The following is a description of a gene set: Human Gene Set: TGCTGCT_MIR15A_MIR16_MIR15B_MIR195_MIR424_MIR497 Genes having at least one occurence of the motif TGCTGCT in their 3' untranslated region. The motif represents putative target (that is, seed match) of human mature miRNAs hsa-miR-15a, hsa-miR-16, hsa-miR-15b, hsa-miR-195, hsa-miR-424 and hsa-miR-497 (v7.1 miRBase). studied in species Homo sapiens, and this is the list of marker genes: MYT1L, ARPP21, DCAF7, TMEM87A, BCL2L2, SOBP, ZKSCAN2, SCOC, QKI, CARM1, ACSBG1, WNT3A, ZYX, APP, RPS6KA3, EIF3A, KCTD1, PLA2G15, PLEKHA1, RUNX1T1, TFAP4, NR4A3, HAS2, UBE2V1, GPR63, DLL1, DEDD, SMAD3, CLOCK, SGK1, ACSL1, VEGFA, TMEM33, EIF4B, OTUB1, CDC42, CPEB3, PCDH17, VSIR, ZCCHC3, TPPP3, PPP2R5C, LAMC1, ADCY10P1, RASL12 (NCBI Gene Id 51285), UBXN10, MIPOL1, EDA, ERC2, GRAMD2B, TMEM87B, ZBTB39, PCDHA11, HOXA3, CREBRF, ELMO2, MAP7, WBP11, VAMP7, PAFAH1B1, ARHGEF5, DYNC1I1, TLE4, PTPN3, CDC37L1, PHF20, SLC9A6, STRADB, GORASP2, ARMCX2, ARFGAP2, PCDHA3, CADM1, YWHAH, MIB1, GABBR1, MAP2K3, PCDHA12, KIF5B, SPEN, SMYD5, CSDE1, ELL, EPB41L4B, DCUN1D4, PITPNA, SIX4 (NCBI Gene Id 51804), USP25, PIM1, ATF7IP2, PURA, EPHA1, CHRD, N4BP1 (NCBI Gene Id 9683), GRIN1, ITGA2, GREB1L, YWHAQ, LMAN2L, KBTBD2, BTRC, CLASRP, CDS2, ETFRF1, OTUD4, SYDE1, CCDC28A, ESRRA, SIGMAR1, CACUL1, RNF144B, TBP, ZNF609, ARHGEF9, SCARF1, PNPLA6, CCND2, MMD, E2F7, PRDM4, BCL9L, MICU1, LRIG2, SNTB2, FGF2, ARHGAP5, CAPN6, SEH1L, WNT7A, PCDHA7, POU3F2, MYLK4, DEF8, CLCN5, PCDHA13, PPP2R1A, NEXMIF, BACH2, PIEZO1 (NCBI Gene Id 9780), SYNRG, TGIF2, PIAS1, DCBLD2, ACTR1A, KPNA4, MOB3B, ZHX1 (NCBI Gene Id 11244, zinc fingers and homeoboxes 1), ENAH, KCTD8 (potassium channel tetramerization domain containing 8), OGT, ZNF362, GHR, MTSS1, UBFD1, CHD5, PLEKHH1, LITAF, TMEM135, GNAI3, NFATC3, PCDHAC2 (protocadherin alpha subfamily C, 2), PHF19, ANGEL1, TRPM2, PPM1A, SYNE1, CCDC6, SLC7A2, VPS9D1, SPTLC1, LRP1B, ACSL4, PCDHA4, PCDHA2, POM121, SLC4A4, ANK2, KCNAB1, ZMYM6, WDR47, RNF217, TFAP2D, TCAIM, ATP2B2, SYPL1, APLN, PAK5, ADGRL2, KALRN, SELENOI, COL12A1, DACH1, EXOC3L2, NRP2, ADGRL1, MAP3K3, LATS2, CNIH2, PTCH1 (patched 1), PHF20L1, PCDH9, KREMEN2, TBPL1, GPN1, TSC22D3, ARHGAP12, ADRB2, PCGF5, ADGRB1, RAB10, LUZP1, ANKRD13B, MAPK3, SYNJ1, RARB, UBE2J1, TBL1XR1, RSBN1, TMEM255A, G0S2, KIF1B, LTB, MYLK, ZNF532, LRP6, AXIN2, CHORDC1, TFAP2A, AFF4, BCL2, RSPO3, PURB, KCNJ2 (potassium inwardly rectifying channel subfamily J member 2), RNF125, JADE2, DCAF5, SMAD7, SOCS6, CDC42EP2, PSD3, BCAP29, IL17RE, EPHA7, RYBP, NUP50, AHCYL2, CUL2, PDCD4, TMCC1, CALM1, WDTC1, GSE1, C8orf58, AK4, ASPH, ADAMTS5, PDK4 (NCBI Gene Id 5166), ARID1A, COPS7B, TRIM2, EYA1, SLC6A4, RNF138, AMMECR1, YOD1, HSPA4L, NAV1, SEMA3D, CD164, UBR3, ACTR2, CLUH, TAF15, SLC13A3, BHLHE41, RAD23B, PSME3, PPM1E (NCBI Gene Id 22843), KCNN4, BDNF, PCDHAC1, CARD10, CSNK1G1, RELN, SOWAHC (sosondowah ankyrin repeat domain family member C), PCDHA10, HOXC11, RTL3, HDGF, TAB3, NSG1, DLEU7, HELZ, SUMO3, RAP2C, CHRNE, FURIN, PHLPP2, RNF43, ACOX1, SFXN5, LRIG1, UBE2Q1, PCDHA9, SEMA6D, WEE1 (WEE1 G2 checkpoint kinase), SMURF1, UBE4B, RBM6, PHIP, SETD3, INPP5J, GPATCH8, CERS1, C1orf21, SPSB4, NEBL, ARHGAP20, SMARCD2, CDX2, SRPK1, DSEL, DMTF1, SMAD5, RECK, MRAS, ISOC1 (NCBI Gene Id 51015), CAB39 (calcium binding protein 39), VAT1, RBBP6, TUBA1A, SYNDIG1, SIPA1L2, PLPP1, PSKH1, ZHX3, HIGD1A (NCBI Gene Id 25994), ZBTB46, CASKIN1, TRIP10, LRRFIP2, TMEM121B, TMEM74B, ABCC5, RETREG2, CASR, ARMC5, SNRK, ADAMTS18, PLXNA2, CAPN3, ABHD13, BACE1, USP14, LRRC55, SLITRK1, FAM133B, BORCS6 (BLOC-1 related complex subunit 6), FRMPD1, FSD1, CACNB1, PCDHA1, RICTOR, PLAG1, RAF1, EZH1, CAPZA2, SLC25A35, STX1A, POLR3F, PDIA6, PRPF38A, PI4KB, SERBP1, B4GALT1, CCNE1, LYPLA2, SYT8, GGA3, C12orf76 (NCBI Gene Id 400073), KRTAP11-1, STXBP1, TSPYL2, PDLIM5, FCHSD1, ARL10, STK33, NF2, PID1, MAP3K4, ATP1B4, RTF1, WIPI2, ZSWIM3, KLHL18, DMTN, MSH5, GOLGA1, RASGEF1B, KBTBD4, WAPL, CDC25A, HIRA, PCBP4, SPTBN2, DLL4, SEPTIN2, BMX (NCBI Gene Id 660), SIDT1, DHX57, ZNF622, COPS7A, SNX33, AP2A1, AGO4, PIP4P2, CDV3, GRM7, WWP1, PDPR, RASSF5, BACE2, KMT2A, PIK3R1, PEX13, HOXA10, VAMP8, ARL2, KRTAP4-4, C1QL3, TLK1, AVL9, MAPRE1, HTR2C, NLGN1, DRD1, MGAT4A, LRRN3, PCDHA6, SPRED1, HAPSTR1, ZBTB10, IGF2R, CDK5R1, AKT3, SLC12A2, CHEK1, PEX5, CC2D1B, TLL1, FAM81A, MINK1, MTMR4, TSPAN5, MAPK1IP1L, E2F3, DUSP3, CX3CL1, COPS2, SON, HMGA1, TGFBR3, DCLK1 (doublecortin like kinase 1), STOX2, OMG, KDSR, SCN4B, ESRRG, BAG5, PCDHA5, GLUD1, OTOGL, CRKL, ZBTB9, MAP4, SGCD, CCN4, CNN1, RAD51C, PPP1R11, FERMT2, ATG14 (autophagy related 14), TAF5, ZMYM2, SIAH1, CAMKV, PAPPA, STK19, KIF5A, MAP2K1, MYB, HTR4, PCMT1, BAZ2A, SNX16, ATXN2, USP15, ITPR1, RAB4B, BCR, PEDS1-UBE2V1, PTHLH, LYST, PBX3, DDX3Y, SINHCAF, ARCN1, RET, PPP3CB, NXPH1, BFAR (NCBI Gene Id 51283), SLC36A1, CPSF7, MED26, SPRY4, SH3GL2, CBX4, TRAM1, ZKSCAN1, DYNC1LI2, SESN1, HOXC8, SUCO, MBD1, CHAC1, PDIK1L, CCNT2, CLDN2, CAMSAP1 (calmodulin regulated spectrin associated protein 1), KLC4, CD28, CPD, FZD10, KLC2, RNF111, SPRYD3, GK5, GSKIP, DOLPP1, DDX3X, AGO1, RANBP3, UBAP1, CDCA4, IL1RAPL1, PCDHA8, SRSF11, CRIM1, PPP6R3, SRSF5, USP42, SH3BGRL2, KIF21A, STXBP3, RAB11FIP2, LY6E, PISD, ZBTB44, NCS1, ARHGDIA, CHPT1, ADAMTSL3, ACVR2A, COBLL1, ZCCHC2, PPM1D, SATB2, TNRC6B, FAM91A1, CBFA2T3, ZIC1, KIF23, CASZ1, PHLDA3, FBXW7, ACACA, MAMSTR, GLUD2, AKAP11, YTHDC1, BTG2, CPEB2, SLC4A7, ABCG4, VAV2, SUPT16H, PPP6C, COL24A1, CDK17, GATAD2A, MTFR1L, ARL8B, OTX1, CRACR2B, VAMP1, MOB4, ZFC3H1, PYM1, DHDDS, EGLN2, IRF2BPL, ANO3, ZC3H12B